The following is a description of a gene set: species: Mus musculus Mutational activation of ras genes is required for the onset and maintenance of different malignancies. Here we show, using a combination of molecular physiology, nutritional perturbations and transcriptional profiling, that full penetrance of phenotypes related to oncogenic Ras activation, including the shift of carbon metabolism towards fermentation and upregulation of key cell cycle regulators, is dependent upon glucose availability. These responses are induced by Ras activation, being specifically reverted by downregulation of the Ras pathway obtained through the expression of a dominant-negative Ras-specific guanine nucleotide exchange protein. Our data allow to link directly to ras activation the alteration in energy metabolism of cancer cells, their fragility towards glucose shortage and ensuing apoptotic death. Mouse Gene Set: CHIARADONNA_NEOPLASTIC_TRANSFORMATION_KRAS_UP Genes up-regulated in transformed NIH3T3 cells (fibroblasts transformed by activated KRAS) vs normal cells. from publication Chiaradonna F, Sacco E, Manzoni R, Giorgio M, Vanoni M, Alberghina L (PMID 16607279), and this is the list of marker genes: Ivns1abp, Kcnn4, Nfkbia, Efnb2, Hmgn2, Erh (NCBI Gene Id 19068), Ugt1a2, Ank, Gtf2a2, Sephs2, Lum, Zwint, Pcna, Grem2, Rrm2, Rad51, Rrm1, Myo1b, Plscr1, Top1, Tgfb1, Erdr1 (erythroid differentiation regulator 1, this gene is present on both X (Erd1x) and Y (Erd1y) chromosomes), Ngef, Prkcb, Dnmt1, Prl2c2, Noct, Uba2 (NCBI Gene Id 53913), Dhx9, Evl (NCBI Gene Id 14026), Nav2, Ccnd1, Gja1, Plpp3, St6gal1, Ctsb, Cytip, Tnfaip2, Rasa1, Igf2r, Ppid, Sema7a (NCBI Gene Id 78407), Rangap1, Slc6a8, Smc2, Marcksl1, Dlk1, Ilf2, Hmga2, Pdpn, Hprt1, Rbl1 (RB transcriptional corepressor like 1), Cask, Ctsl, Aurka, Adam19, Arxes2, Xlr, Ccl2, Nap1l1, Slbp, Uhrf1, Areg, Rbm3, Fut8, Bach1, Hmgb3, Klra4, Cdc7, H2ax, Klra13-ps, Plk4, Psma3, Set, Spp1, Rfc5, D17H6S56E-5, Ereg (NCBI Gene Id 269673), Tmsb4x, Apbb1ip, Tpbg, Crisp1, Vcam1, Pclaf, Snu13, E2f8, Fdx1, Mrpl18, Ncam1, Ncaph, Casp4, Top2a, Evi2a, Tiparp, Itgb7, Etv4, Mapk6, Cks1b, Il1rl1, Thbs2, Has2 (hyaluronan synthase 2), Cenpa, Med10, Crabp1, Hnrnpd, Bzw2, Bnc1, Sptssa, Ifi202b, 1810030O07Rik, Fam3c, Apcdd1, Spred2, Slc12a2, Lsm8, Pola1, Ahcyl, Nfe2l2, Angptl2, Tcf12, Topbp1, Gdnf, Rgs16, Ssrp1, Cenpv, Ergic3, Myef2, Phlda1, Anp32e, Itga6, Timp1, Sms, Tubb6, Fignl1, Pcdh7, Ube2d2a (ubiquitin-conjugating enzyme E2D 2A), Haus3